Given this list of marker genes TP53I3, YWHAQ, VDR, MDM2, IGFBP3, JAG2, NOTCH3, SMARCD3, CDKN1A, here is a description of the gene set: from publication Kommagani R, Caserta TM, Kadakia MP (PMID 16462763) Genes changed in H1299 cells (non-small cell lung cancer, NSCLC) transiently transfected to express the TP63 gamma splice variant. Human Gene Set: KOMMAGANI_TP63_GAMMA_TARGETS studied in species Homo sapiens p63, a p53 homolog has been shown to play a role in development and cancer. p63 is essential for both commitment of ectoderm to stratified epithelia and for the proliferative potential of epithelial stem cells. p63 knockout mice are born with severe development defects and lack organs of epithelial origin. In addition, p63 has also been shown to play a role in cancer development through the differential regulation of genes with tumor suppressor function and genes involved in metastasis. In order to understand the role of p63 in cancer and development, genes that are specifically regulated by p63 but not p53 were identified. In this study, we provide evidence that p63gamma specifically upregulates vitamin D Receptor (VDR). In contrast, p53 does not appear to be involved in upregulation of VDR expression. Additionally, we demonstrate that a naturally occurring p63 missense mutant, p63gamma (R279H) and p14(ARF), both act in a dominant negative manner to inhibit p63gamma-mediated upregulation of VDR. Furthermore, using chromatin immunoprecipitation assays, we demonstrated that p63 directly binds to the VDR promoter in vivo. Our findings clearly demonstrate that VDR is a direct target of p63 and suggests that p63 may play a role in cancer and differentiation through modulation of the VDR pathway.